Given this list of marker genes Prdm9, Fbxo5, Piwil2, Eif4g3, Dmrt1, here is a description of the gene set: Mouse Gene Set: GOBP_POSITIVE_REGULATION_OF_MEIOSIS_I studied in species Mus musculus Any process that increases the rate, frequency, or extent of meiosis I, a cell cycle process comprising the steps by which a cell progresses through the first phase of meiosis, in which cells divide and homologous chromosomes are paired and segregated from each other, producing two daughter cells.